Given this list of marker genes ITGB3, ACTG1, FN1, MAP2K1, VCL, MAPK3, IQGAP1, RAF1, FGA, ITGA2B (integrin subunit alpha 2b), YWHAB, CALM1, CAMK2A, KSR1, CNKSR1, MAPK1, CNKSR2, FGG, RAP1B, BRAF, CAMK2D, TLN1, CAMK2G, CSK, ARRB2, ACTB (NCBI Gene Id 60), HRAS, VWF, MARK3, KSR2, JAK2, NRAS, ARRB1, RAP1A, ARAF, SRC, MAP2K2, FGB (NCBI Gene Id 2244), APBB1IP, KRAS, CAMK2B, here is a description of the gene set: part of: Oncogenic MAPK signaling studied in species Homo sapiens RAF1, also known as CRAF, is mutated in a number of germline RASopathies including Noonan Syndrome, Costello Syndrome and others, and also at low frequency in a number of cancers. Activating mutations cluster around conserved region 2 (CR2) which is required for regulation of the protein and the activation segment in CR3. Reactome Pathway: Signaling by RAF1 mutants